The following is a description of a gene set: species: Homo sapiens Genes up-regulated in blood vessel cells from wound site. Human Gene Set: ROY_WOUND_BLOOD_VESSEL_UP Chronic wounds represent a substantial public health problem. The development of tools that would enable sophisticated scrutiny of clinical wound tissue material is highly desirable. This work presents evidence enabling rapid specific identification and laser capture of blood vessels from human tissue in a manner which lends itself to successful high-density (U133A) microarray analysis. Such screening of transcriptome followed by real-time PCR and immunohistochemical verification of candidate genes and their corresponding products were performed by using 3 mm biopsies. Of the 18,400 transcripts and variants screened, a focused set of 53 up-regulated and 24 down-regulated genes were noted in wound-derived blood vessels compared with blood vessels from intact human skin. The mean abundance of periostin in wound-site blood vessels was 96-fold higher. Periostin is known to be induced in response to vascular injury and its expression is associated with smooth muscle cell differentiation in vitro and promotes cell migration. Forty-fold higher expression of heparan sulfate 6-O-endosulfatase1 (Sulf1) was noted in wound-site vessels. Sulf1 has been recently recognized to be anti-angiogenic. During embryonic vasculogenesis, CD24 expression is down-regulated in human embryonic stem cells. Wound-site vessels had lower CD24 expression. The findings of this work provide a unique opportunity to appreciate the striking contrast in the transcriptome composition in blood vessels collected from the intact skin and from the wound-edge tissue. Sets of genes with known vascular functions but never connected to wound healing were identified to be differentially expressed in wound-derived blood vessels paving the way for innovative clinically relevant hypotheses. from publication Roy S, Patel D, Khanna S, Gordillo GM, Biswas S, Friedman A, Sen CK (PMID 17728400), and this is the list of marker genes: SEL1L3, ZWINT, NRP1, CHN1, HYAL1, SGCB (NCBI Gene Id 6443), COL5A2, PCDH17, STC1, CDH5, XAF1, GALNT2, PEA15, ATG4A, ANGPT2, COL5A3, GNA12, PLAU, MSX1, SRSF11, ANXA6, SLCO2A1, FKBP1B, FBXL7, GBP1, CYFIP2 (cytoplasmic FMR1 interacting protein 2), RAB31, S100A4, TIMP1, BMP1, LUM, COL3A1, KDM5D, NID2, MMP1, CCN1, THY1, TES, ANGPTL2, PLXDC1 (NCBI Gene Id 57125), POSTN, KCNJ8, STOM, DENND4B, HEG1, VCAN, COL4A1, MCTP1, HLA-DRB4, SULF1 (NCBI Gene Id 23213)